The following is a description of a gene set: studied in species Mus musculus Mouse Gene Set: GOCC_EUKARYOTIC_TRANSLATION_INITIATION_FACTOR_3_COMPLEX_EIF3M An eukaryotic translation initiation factor 3 complex that contains the PCI-domain protein eIF3m., and this is the list of marker genes: Eif3d, Eif3m, Eif3c, Eif3h, Eif3f, Eif3b, Eif3i, Eif3a